Given this list of marker genes COL5A3, CACNA1S, ST8SIA2, CACNB1, COL3A1, COL6A2, COL5A2, CACNA1D, NCAN, CNTN2, COL4A2 (collagen type IV alpha 2 chain), CACNA1I, COL9A1, COL6A5, ARTN, CACNA1C, COL6A1, NCAM1, GFRA1, COL6A6, COL9A2, GDNF, GFRA4, AGRN, CACNB2, CACNB3, PSPN, COL4A1, COL9A3, CACNA1G, COL4A3, ST8SIA4, CACNA1H, PRNP, NRTN, CACNB4, GFRA2, COL5A1, COL2A1, COL4A5, COL6A3 (NCBI Gene Id 1293), COL4A4, here is a description of the gene set: Human Gene Set: REACTOME_NCAM1_INTERACTIONS species: Homo sapiens NCAM1 interactions